Given this list of marker genes GBA1, RERE, DYM-AS1, STAT3, ARNT, ANO8, STX8, C2orf76, CMC2, IFTAP, ZNF324B, ABCA15P, YBX1P2, ZFC3H1, MRPL54, SLC24A1, PCYT1A, NDUFV3, ADAP2, RAB27A, MTND5P11, MTCO3P12, EPHX2, DMRTC2, ZNF689, GRB2, NME1-NME2, GUSBP2, PIGB, ZBTB40, LYPD4, S100A13, ZNF566, SAMD4B, ISLR2, C22orf46P, CABIN1, SLC39A11, RABGAP1L, RNU6ATAC, TRIP4, ZNF823, THAP2, SLC25A32, RPL27, ATP6AP2, EPCIP-AS1, ITFG2-AS1, RNU4-71P, DUSP6, MT-TF, WDR36, SCNM1, NCOR2, FAM91A1, HMBOX1, MTF2, LINC02846, C18orf21P1, PAXBP1, PCLAF, XPC, LRRC51, DCAF13, ZDHHC1P1, NME1, ENPP3, TTC14, ZNF226, SEMA6A, INO80C, DMAP1, LINC00240, SORD2P, PEAR1, CFAP52, LINC01132, SNU13, BAG1, BRCA1, PIGBOS1, CDIN1, SMG8, MT-RNR1, NUMA1, S100PBP, COX7A2, RUVBL1, FEM1C, AURKAIP1, CHMP5, TARS2, HCP5, MED23, DBI (diazepam binding inhibitor, acyl-CoA binding protein), FBXO27, EHMT1, EDEM2, LYSMD1, ZBTB45, HLA-DQB1, INTS14, NDUFB7, ADRA1A, TMEM242, DCAF4, H2AC6, RN7SL824P, GTPBP3, TMEM179B, YARS1, ODAD4, TEFM, GNAL, MIA3 (MIA SH3 domain ER export factor 3), COMMD4, BAZ2A, TRAK1, APBA3, NDUFAF1, ZNF461, MAP2K5, KCNK1, RPL37 (NCBI Gene Id 6167), TMEM242-DT, INTS9, MTR, TTC14-DT, JPX, BMS1, NBR2, ZNF780B, here is a description of the gene set: from publication Yevshin I, Sharipov R, Kolmykov S, Kondrakhin Y, Kolpakov F (PMID 30445619) Genes containing one or more binding sites for (ZNF669) in their promoter regions (TSS -1000,+100 bp) as identified by GTRD version 20.06 ChIP-seq harmonization. Human Gene Set: ZNF669_TARGET_GENES species: Homo sapiens